Given this list of marker genes UNC119B, UNC119, CRCP, ATF6 (activating transcription factor 6), PDIA4, PRKACA, THAP7, MSMO1, MLLT3, COMT, TOP2A, AGL, FASLG, ANXA2, IDI1, PRDX4, TPI1, FDFT1, MRPL45, XCL1, FAM162A, TAMM41, DHCR7, ZDHHC16, TSPAN31, ATF5, CSNK2A2, TNFRSF9, BIRC5, OLA1, HASPIN, STK39, SOX1, ECPAS, SKAP2, MAEA (macrophage erythroblast attacher, E3 ubiquitin ligase), PGAM1, BCL2A1, MT2A, SLC37A4, SULT2B1 (NCBI Gene Id 6820), RNF14, HMGCR, POMP, YBX3, GZMB, HERPUD1, CYB5B, CRTAP, HIP1R, LGALS1, MVD, RNASEH2B, IFI30, CKAP5, VEGFA, RFC2, ENOPH1, MRPL17, GLRX, ANLN, IL3RA, CTLA4, CHCHD10, SCD, SERPINB9 (serpin family B member 9), ACVRL1, PAFAH1B3, GTF2E2, BLMH, RIOX2, IRF8, TRIB3, CAPG, RCN2, RHOQ, S100A6, FKBP2, ADORA2A, LDAF1, PRIM2, XPNPEP1, MAPKAPK2, PLP2, CENPK, BST1 (bone marrow stromal cell antigen 1), POLB, YJU2, MAP3K8, MKI67, PTGR1, SQLE (squalene epoxidase), PDZD11, NVL (NCBI Gene Id 4931), TIMM9, CCR5, CCDC6, HDHD2, GALK1, DDIT4, AP2A2, KIT, PLEKHB2, GPR65, MT1E, HRAS, AHNAK, HAX1, LGALS3, NUSAP1, CD93, SLC30A4, MRPL18, PGM1, UGDH, CNPY2 (canopy FGF signaling regulator 2), SYCE2, TMEM97, ABCD3, CARS1, NOCT, ELMOD3, JMJD6, RCAN1, LXN (NCBI Gene Id 56925), TUBG1, KLRK1, IL2RA, HK2, CKS1B, XPOT, PMM1, SLC2A1, PREP, KGD4, MRPS22, IL12RB2, MEST, RSPH3, HOPX, DCK, GBE1, GGH, ARL2, PLA2G12A, XDH, MFN1, RBPJ, H2AB2, CYP51A1, NDRG1, ADSS1, MAD2L1, CLIC4, DECR1, SAP30, IFNG, HCFC1R1, HMBS, DTD2, SAAL1, FBXO6, SEMA4F, RAD50, PSMD12, AEBP2, CD160, RFC4, SMPD1, CKB, SLC2A3, TG, PCYT2, SIVA1, NBN, TGDS, PGLYRP1, ANXA4, CDKN2AIPNL, TACC3, TPD52L2, BHLHE40, GADD45G (NCBI Gene Id 23575), RFC5, RB1, ARFGAP3, DDX52, SNRNP25, CD200, APBA3, REXO5, AIMP2, MTHFD2, FDPS, ACOT7, CISD1, SPAG7, IL18R1, IARS1, RNH1, here is a description of the gene set: Differentiation of naive CD8 T cells into cytotoxic effector cells requires three distinct signals- antigen (signal 1), costimulation -B7-1 (signal 2) and cytokine, either interleukin-12 or interferon-a/b (signal 3). Interaction of naive CD8 T cells with antigen and B7-1 programs cell division and proliferation whereas the presence of cytokines- IL-12 or IFNa/b promote survival, differentiation and memory establishment. In the absence of signal 3, the cells interacting with antigen/B7-1 undergo tolerance induction. The objective of this study was to elucidate the mechanisms how the provision of signal 3 promotes differentiation and averts tolerance induction in CD8 T cells. Trichostatin A is a pharmacological agent that inhibits histone deacetylase activity, hence regulating chromatin structure and gene expression and differentiation in many cell types. Gene signature profiles of IL-12, IFNa/b and trichostatin A stimulated cells were compared to elucidate the molecular mechanisms of gene regulation. Oligonucleotide microarray analysis is carried out to determine the extent and molecular nature of the CD8 T cell differentiation program induced by IL-12 or IFNa/b in concert with antigen and B7-1 signal. from publication Agarwal P, Raghavan A, Nandiwada SL, Curtsinger JM, Bohjanen PR, Mueller DL, Mescher MF (PMID 19592655) Human Gene Set: GSE15930_NAIVE_VS_72H_IN_VITRO_STIM_IL12_CD8_TCELL_DN Genes down-regulated in comparison of CD8 T cells at 0 h versus those at 72 h after stimulation with IL12. species: Homo sapiens